The following is a description of a gene set: species: Mus musculus Any process that modulates the frequency, rate or extent of leukocyte apoptotic process. Mouse Gene Set: GOBP_REGULATION_OF_LEUKOCYTE_APOPTOTIC_PROCESS, and this is the list of marker genes: Fadd, Bcl2l11, Cd3g, Noc2l, Ccl19-ps4, Il2 (interleukin 2), Mir92-2, St6gal1 (beta galactoside alpha 2,6 sialyltransferase 1), Birc7, Bcl2, Irs2, Lgals3, Sirt1, Mir93, Ccl21f, Mir19b-2, Foxp1, P2rx7, Il3, Hcar2, Bmp4, Nr4a3, Fnip1, Ccl21e, Pdcd7, Mir19b-1, Pik3cd, Selenos, Pdcd1, Tgfb2, Ccl21a, Cd47, Ccr5, Bax, Rorc, Bbc3, Dock8, Mef2c, Il18, Bcl10, Ccl19-ps3, Ccl19-ps5, Mir20b, Myc (myelocytomatosis oncogene), Jak3, Nod2, Rag1, Hif1a, Il7r, Ccl21d, Itpkb, Prkd2, Tsc22d3, Cdkn2a, Ccl19-ps6, Slc7a11, Mif, Serpinb9, Vhl, Bcl2a1a, Mir106b, Ormdl3, Cxcr2, Cd274, Hsh2d, Cd44, Gas6 (growth arrest specific 6), Ccr7, Efna1, Hcls1, Nf1, Perp, Nfkbid, Siglec1, St3gal1, Cxcl12, Ido1, Slc39a10, Ptcra, Bcl11b, Tnfrsf4, Zc3h8, Pten (NCBI Gene Id 70161), Il10, Prkcq, Bcl3, Adam17, Ccl19-ps1, Ccl19, Gimap8, Cd74, Aurkb, Ada (adenosine deaminase), Trp53, Fcer1g, Slc46a2 (NCBI Gene Id 80480), Arg2, Fcgr2b, Pip, Kifap3, Mir363, Pnp, Tnfsf4, Bcl2l1, Adam8, Rapgef2, Anxa1, Kitl, Mertk, Ccl21b, Stat5a, Ripk3, Blm, Pik3cb, Mir92-1, Lyn (LYN proto-oncogene, Src family tyrosine kinase), Wnt5a, Mir106a, Gpam, Ccl5, Fcmr, Cd24a, Prelid1, Ghsr, Mir18b, Axl, Mir25, Cd27, Casp8